The following is a description of a gene set: Mouse Gene Set: GOBP_NEGATIVE_REGULATION_OF_POST_TRANSCRIPTIONAL_GENE_SILENCING species: Mus musculus Any process that decreases the frequency, rate or extent of the inactivation of gene expression by a posttranscriptional mechanism., and this is the list of marker genes: Zmpste24, Lin28b, Elob, Hnf1a, Elavl1 (ELAV like RNA binding protein 1), Bcdin3d, Zc3h10, Il6, Fmr1, Dnd1, Zswim8, Mir361, Trp53, Adar, Lin28a, Eloc, Stat3, Tent2 (terminal nucleotidyltransferase 2), Mecp2